Given this list of marker genes Gapdhrt (glyceraldehyde-3-phosphate dehydrogenase, retrotransposed), Serpinb9b, Akt1, Gapdh-ps15, Serpinb9h, Spink1, Spock1, Bin1, Serpinb1a, Serpinb1b, Serpinb9c, Serpinb6c, Spink6, Serpinb9e, Serpinb9g, Vtn, Serpinb9f, Tmed10, Serpine1, Stfa1, Timp3, Serpinb6b, Spock3, Serpinb9d, Gapdh, Serpinb13, Timp1, Spink2 (serine peptidase inhibitor, Kazal type 2), Crb2, Reck, Serpinb9, Gapdhrt2, Fetub, Serpinb6e, Serpinb6d, Serpinb6a, Serpinb8, Serpinb1c, Stfa2, here is a description of the gene set: Any process that decreases the frequency, rate or extent of endopeptidase activity, the endohydrolysis of peptide bonds within proteins. Mouse Gene Set: GOBP_NEGATIVE_REGULATION_OF_ENDOPEPTIDASE_ACTIVITY studied in species Mus musculus